The following is a description of a gene set: Mouse Gene Set: GOBP_POSITIVE_REGULATION_OF_CANONICAL_WNT_SIGNALING_PATHWAY Any process that increases the rate, frequency, or extent of the Wnt signaling pathway through beta-catenin, the series of molecular signals initiated by binding of a Wnt protein to a frizzled family receptor on the surface of the target cell, followed by propagation of the signal via beta-catenin, and ending with a change in transcription of target genes. species: Mus musculus, and this is the list of marker genes: Ilk, Pin1, Fgfr2, Rspo1, Ube2b, Tbl1x, Tgfb1 (transforming growth factor, beta 1), Tnks (NCBI Gene Id 97475), Ruvbl1, Fgfr3, Ppm1n (NCBI Gene Id 97371), Tmem198, Egfr, Nle1, Rspo3, Rspo2, Col1a1, Map3k1, Wnk2, Eda, Trpm4, Tmem198b, Fgf2, Zbed3, Wnt3a, Dapk3, Csnk1g2, Sbno1, Wnt10b, Fam53b, Sfrp2, Gpc5, Lmx1a, Sox4, Sfrp1, Usp34, Lgr5, Hhex, Gid8, Atp6ap2, Bmal1 (NCBI Gene Id 11865), Peg12, Lrrk1, Rbpj, Usp47 (NCBI Gene Id 74996), Sulf2, Csnk1d, Ubr5, Ppm1b, Spin4 (spindlin family, member 4), Scel, Ddx3x, Wnk1, Zeb2, Bambi, Frat1 (frequently rearranged in advanced T cell lymphomas), Jrk, Rspo4, Adnp, Ctdnep1, Ror2 (NCBI Gene Id 26564), Dlx5, Egf, Plekha4, Potefam3a, Lgr4 (leucine-rich repeat-containing G protein-coupled receptor 4), Lrrk2, Fgf9, Tnks2, Tbl1xr1, Pin1rt1, Xiap, Fzd9, Csnk1g3, Rps12, Thra, Csnk1e, Ptk7, Rnf220, Daam2, Ccar2, Adgra2, Fgf10, Nfkb1, Aspm, Usp8, Wls, Gskip, Smad3, Csnk1g1, Sfrp4, Ankrd66, Amer1, Gprc5b, Ppm1a, Caprin2, Gpc3, Nrarp, Cdh3 (cadherin 3, NCBI Gene Id 12560), Vps35 (VPS35 retromer complex component), Vcp, Lypd6, Prdm15, Yap1, Ttc21b, Kank1, Rnf146, Reck, D1Pas1, Tmem9 (transmembrane protein 9), Dkk2, Potefam3b, Ppp2r3a, Dact1, Sema5a, Src